Given this list of marker genes Avp, Vmn2r116, Oxt, Ncoa2, Thra, Avpr1a, Ncoa1, Drd5, Thrb, Esp1, Ppp1r1b, here is a description of the gene set: studied in species Mus musculus Mouse Gene Set: GOBP_REGULATION_OF_FEMALE_RECEPTIVITY Any process that modulates the frequency, rate or extent of the willingness or readiness of a female to receive male advances.